The following is a description of a gene set: from publication Chen Y, Wang X (PMID 31504780) Genes predicted to be targets of miRBase v22 microRNA hsa-miR-6128 in miRDB v6.0 with MirTarget v4 prediction scores > 80 (high confidence targets). studied in species Homo sapiens Human Gene Set: MIR6128, and this is the list of marker genes: ZNF285, RTL5 (retrotransposon Gag like 5), RAB6A, ATAD2B, AMBRA1, JADE1, ELAVL1, AKR1D1, SRSF9, SLC30A9, PTBP1, MAP3K1, RORA, TWSG1, MSRB3, RALGAPB, EOGT, SPON1 (NCBI Gene Id 84806), ASXL2, TESPA1, MTX3, LHX9, NOTCH3, SMURF1, ARMC1, UQCRB, UBN1, FMC1-LUC7L2, MBNL2, IL6ST, FNIP2, CDK6, CHCHD3, CD164, ZMYND11, SUDS3, CCDC28A, NKRF, UBE2R2, PIM1, NALF1, SLC38A2, LUC7L2 (NCBI Gene Id 51631), STC1, SLC30A6, CBLB, DLAT, TNIK, CLCN3, TMEM169, LATS1, SOCS2, ATF7IP, QTRT2, PRND, FRMD4B, TRIM10, ESYT3, TIPRL, TMOD2, SUMO2, GATA6, LRP2, RSPRY1, KIAA1217, ZFHX3, FNBP4, BIVM, TANC2, GID8, GPR158, PON2, TNKS2, CXADR, SNAPC3, WDR48, UGT2A1, WIF1, SPTLC1, PAQR3, DCLK3, B3GNT2, ZBTB8A, BACH2, RALA, BCL11A, SLC24A3, SULF1, NCALD, TENT5A, BRD10, FOCAD, GRIA3, CDH1, MANSC1, RNF8, LANCL1, EPB41L2, KDSR, EVC, HAPSTR2, PLAGL2, ZNF711 (NCBI Gene Id 7552), MBIP, GPR3, DOLPP1, GNPDA2, PRKD3, TIA1, ZC3H4, CTTNBP2NL, CLASP2, CNTNAP3B, ARHGEF39, MEOX2, AFF4, ST6GALNAC3, TMEM30A, SESN3, G3BP2, MSN (moesin), SGIP1, ZNF280C, IFNGR2, ZFPM2, SGMS1, NR3C1, LENG8, MIPOL1, SHANK2, ZNF281, EGLN3, BEST1, SEMA4D, OAS3, GCLC, NPR1, SOX6, BIK, YIPF4, FAM210B, DPY19L4, EDEM3, OAF, MYL12B, HIF3A, NCOA1, ARL3, GJC1, ENPP5, ING3, ZNF326, COPG2, MEIS2, STAT3, ATP6V0C, ERCC2, FUBP1, TMEM217, ARB2A, CAMK1D, ETNK1, USP45, CEBPZ, NFATC3, CCR1, UGT2A2, PHC3, ETS1